Given this list of marker genes FLI1, SKP1, ZNF436, FBXW11 (NCBI Gene Id 23291), MTHFD1, KTI12, GALNT10, ABCB7, TRAF3, ARPC3, PARP2, ITGA6 (NCBI Gene Id 3655), WNT2B, PXN, AKAP1, CASC3, ASB4, TMOD2, DNAJB8, DGKE, IKBKB, TPD52, THSD1, PTTG1, ULK1, SATB1, TTC19, SSR1 (NCBI Gene Id 6745), FAM20B, LLGL1, ETHE1, ASXL1, GCA, NUSAP1, NELFB, ZNF24, TACSTD2, PITPNC1, MED20, ZNF346, ANKRD13C, MAML1, MANSC1, GOLGA7, C11orf54, QRSL1, TNPO2, ASAH1, FAM8A1, QKI (NCBI Gene Id 9444), ADGRE5, MCFD2, RETREG1, HACD4, ANKRD46, HEXA, FCGR3A, MAGEE1, MYL12B, STT3B, RCOR3, TP53I13, CYRIB, TM9SF2, ADD1, AGRN, CPNE1, PPP2R2A, UQCRB, UBQLN4, RHOBTB2, ABCC3, AGPAT5, HMBOX1, NEK9, TEAD4, ARHGEF18, PCLAF, GPRASP1, DGKG, THRA, MRPL11, BACH1, CHMP4B, ATF1, UBXN2A, RPGR, PSMG2, C6orf136, INTS8, SERINC1, NUP35, HLCS, ARL14EP, NADK, GRIN2B, WDFY1 (NCBI Gene Id 57590), IFNGR1, YTHDF1, ERF, MTHFR, MAPK14, POLR2D, NHSL2, HACE1, IVNS1ABP, EFNB1, POLR2B, NCAPD2, FAM13C, TKT, ATP7A, KRCC1, COL4A6, TBX18, TMEM165, NLE1, JAK2, NFATC3, TMUB1, ZWILCH, EFR3A, DPF2, INCENP, C21orf91, TREM1, DGCR8, FAM149B1, FNTB, BLTP3A, AMMECR1, SLC25A15, HP1BP3, SOS2, HHEX, PLEKHA1, ECSIT, BAG3, MS4A2, PTGS1, FBXO28, CDC7, SMOC2, OR13J1, LYPLA2, RAB10, PPP1R21, SOX21, VPS54, CEACAM21, SLC38A2, NUP85, RECK, POLDIP3, POLR3F, AKTIP, QSOX1, PIP4K2C, CUL4A, CAAP1, DOCK5, EXTL2, PSMD12, SEC22B, ARF3, KYNU, ELF4, LBR, ATP4A, CYB5R4, RPAP3, ACLY, KIF23, CNTN6, C18orf32, RCAN3, SNAPC5, CRIPT, RNF135, B3GALNT2, RHOQ, TADA1, SOX4, LYST, OAT, PRKCE, GSC, SF1, ZNF518B, RTN1, PNPLA7, COL10A1, HNMT, SLC35A1, TRNT1, APP, TIRAP, RRM1, ABCA1, here is a description of the gene set: Human Gene Set: GSE17721_CTRL_VS_CPG_0.5H_BMDC_UP mouse primary BMDCs were stimulated with tlr ligands and gene expression changes were profiled on Affymetrix arrays from publication Amit I, Garber M, Chevrier N, Leite AP, Donner Y, Eisenhaure T, Guttman M, Grenier JK, Li W, Zuk O, Schubert LA, Birditt B, Shay T, Goren A, Zhang X, Smith Z, Deering R, McDonald RC, Cabili M, Bernstein BE, Rinn JL, Meissner A, Root DE, Hacohen N, Regev A (PMID 19729616) Genes up-regulated in comparison of control dendritic cells (DC) at 0 h versus those stimulated with CpG DNA (TLR9 agonist) at 0.5 h. studied in species Homo sapiens